The following is a description of a gene set: Eversion of a hollow organ and exposure, inside out, and protruded through the abdominal wall. Exstrophy studied in species Homo sapiens Human Gene Set: HP_EXSTROPHY, and this is the list of marker genes: MED12, TP63, PAH, CDH11, ISL1, UPB1, KRAS